The following is a description of a gene set: Any process that results in a change in state or activity of a cell (in terms of movement, secretion, enzyme production, gene expression, etc.) as a result of cell-matrix adhesion. Mouse Gene Set: GOBP_CELLULAR_RESPONSE_TO_CELL_MATRIX_ADHESION species: Mus musculus, and this is the list of marker genes: Mmp9, Cdkn2b, Cdkn1a, Dspp, Gstp1